The following is a description of a gene set: studied in species Homo sapiens from publication Huang G, Eisenberg R, Yan M, Monti S, Lawrence E, Fu P, Walbroehl J, Löwenberg E, Golub T, Merchan J, Tenen DG, Markowitz SD, Halmos B (PMID 18593902) Genes up-regulated in H358 cells (lung cancer) by inducible expression of FOXA2 in a Tet-off system. Human Gene Set: HUANG_FOXA2_TARGETS_UP The forkhead transcription factor hepatocyte nuclear factor 3beta (HNF3beta) is essential in foregut development and the regulation of lung-specific genes. HNF3beta expression leads to growth arrest and apoptosis in lung cancer cells and HNF3beta is a candidate tumor suppressor in lung cancer. In a transcriptional profiling study using a conditional cell line system, we now identify 15-PGDH as one of the major genes induced by HNF3beta expression. 15-PGDH is a critical metabolic enzyme of proliferative prostaglandins, an antagonist to cyclooxygenase-2 and a tumor suppressor in colon cancer. We confirmed the regulation of 15-PGDH expression by HNF3beta in a number of systems and showed direct binding of HNF3beta to 15-PGDH promoter elements. Western blotting of lung cancer cell lines and immunohistochemical examination of human lung cancer tissues found loss of 15-PGDH expression in approximately 65% of lung cancers. Further studies using in vitro cell-based assays and in vivo xenograft tumorigenesis assays showed a lack of in vitro but significant in vivo tumor suppressor activity of 15-PGDH via an antiangiogenic mechanism analogous to its role in colon cancer. In summary, we identify 15-PGDH as a direct downstream effector of HNF3beta and show that 15-PGDH acts as a tumor suppressor in lung cancer., and this is the list of marker genes: LHFPL6, DCAF17, SLC7A11, SOCS2, DISC1, TLE4, F2R, TFPI2, MAP2, JAG1, LAMP3, CADPS2, CPM, HLCS, HOMER1, ZFP69B, ACTG2 (NCBI Gene Id 72), NRG1, CLIP4, MCTP1 (NCBI Gene Id 79772), RELB, HPGD, PLEKHA1, FST, FN1, C5, MAFF, KCNV1, RBPMS, PCK2, ENPP1, RGS2, PSAT1, TNFAIP3, ATP6V0A2, TUBB2B, TOX3, GLUL, ACKR3, SPAG1, CHAC1, ASNS, EGR4, CBLB, NR1D1, KAT2B, PAX5 (paired box 5)